The following is a description of a gene set: Human Gene Set: REACTOME_RAP1_SIGNALLING species: Homo sapiens Rap1 signalling, and this is the list of marker genes: RASGRP2, PRKG1, SIPA1, PRKACA, PRKACB, RAPGEF4, RAPGEF3, RAP1GAP, RAP1B, RAF1, RAP1GAP2, YWHAB, RASGRP1, PRKACG, RAP1A, YWHAZ